Given this list of marker genes Trpc7, Vps53, Sncg, Pam, Mapk8ip1, Arfgef1, Atn1, Cdkn1a, Map6, Adgrv1, Nrbp1, Bag5, Plcg2, Pdcl3, Vcp, Slc39a9, Clint1, Vamp8, Ros1, Nanos2 (nanos C2HC-type zinc finger 2), Nme1, Bicd1, Ccnt2, Ankrd13c, Vps4a, Pdlim4 (PDZ and LIM domain 4), Selenom, Zftraf1, Fzd9, Epg5, Pum2, Bcl3, Rtraf, Pde9a, Traip, Synj2bp, Twf2, Exoc1, Atp2a1, Ccl2, Traf6, Cherp (NCBI Gene Id 70519), Maf1, Msn, Angel1, Nox4, Cask, Prkcg, Ankrd13a, Aldob, Erbb2, Dgki, Ctsb, Kif1a, Cdk2ap1, Tpd52l1, Nedd4, Mgat1, Trf, Cul7, Park7, Calcoco2, Galnt3, Sorl1, Hspa1b (NCBI Gene Id 15511), Vldlr, Capn6, Serhl, Slc2a4, Clic4, Map2k1, Myo5b, Rps6kb1 (ribosomal protein S6 kinase, polypeptide 1), Tnks2, Plscr2, Ccnf, Pstpip1, Nppb, Traf4, Tnfsf12, Gdpd5, Vamp3 (NCBI Gene Id 320838), Eif4a1, Tyr, Trim13, Myo9b, Cripto, Thbs3, Atp6v0a2, Hrnr, Ctif, Clic1, Sort1 (NCBI Gene Id 99747), Trim68, Usp20, Syt4, S100a13, Vps33b, Tg, Tesk1, Trim37, Galnt6 (polypeptide N-acetylgalactosaminyltransferase 6), Dnm3, Inpp5k, Oas2, Pde4a, Brsk2, Golga1 (NCBI Gene Id 99313), Adam10, Olfm4, Gsdma2, Ache, Ifitm3, Mob2, Plcz1, Mtmr2, Kalrn, Mcm3, Csnk1d, Bax, Cdh13, Calr, Cops8, Usp33, Ntm, Akip1, Osbpl7, Flrt1, Coro1b, Rab1b, Gak (cyclin G associated kinase), Flna, Traf7, Nfatc1, Cnp, Ccdc38, Magee1, Sirt2, Car4, Ncoa3, Acsl3, Ptprm, Capzb, Tmem100 (transmembrane protein 100), Aqp2, Btk, Alox5, Srfbp1, Nlrc3, Prkn, Klhl7, Npc1, Rnf207, Fasl, Snx5, Rbm4, Mapkap1, Hif1an, Atg7, Fmn2, Vti1a, Xkr8, Irag1, Itga2, Invs, Cdk19, Rps6, Aif1, Sipa1, Apc, Stmn3, Lamc2, Cyba, Cylc1, Cmya5, Map2k2, Stx16, Fam168b, Rab34, Mob4, Slc30a7, Slirp, Sh3gl2, Ppp1r16b, S100a6, Hyal2, Gc, Stx4a, Cdc5lrt1, Rab14, Cav2, Prkd1, Dnajb2, Rad51c (RAD51 paralog C), Ptges, Xrcc3, Ggps1, Rangrf, Jcad, Cyfip1, Cdc5lrt9, Mtpn, Vps52, Kcnd3, Snap47, Egfr, Chodl, Cideb, Ptk2, Cdc25c, Nppa, Aplp1, Stx6, Ldb3, Tmem184a, Kif5a, Flot2, Fzd5, Rab3ip, Cdkn3, Cdh1, Unc45b, Ckap4 (cytoskeleton-associated protein 4), Gad2, Itgb1bp1, S100a4, Cbl, Hip1r, Atp6v0a1, Tenm1, Ap1g1, Lrat, Cpd, Taf8, Epn3, Zdhhc19, Bri3, Ccar1, Osbpl1a, Tsc1, Usp2, Prkce, Csf1, Mrfap1 (Morf4 family associated protein 1), Nfkbie, Cep43, Cabp2 (calcium binding protein 2), Synj1, Bank1, Cops3, Cx3cr1, Ythdc2, Gtpbp4, Hmgcll1, Rep15, Prkcd, Rab3b, Trpc4ap, S100a16, Wwc1, Rasd1, Tsc2, Trappc2l, Atp7a (NCBI Gene Id 51824), Abl1, Crbn, Apex1, Aggf1, Lmtk2, Pde2a (phosphodiesterase 2A, cGMP-stimulated), Fyn, Insl3, Unc45a, Golga2, Pkhd1, Bdnf, Lmna, Syt5, Arfgef2, Atp2c2, Phex, Ddx6, Tmem192, Kcnh1, Mlc1, Gper1, Eif2ak2, Sorbs2, Dgat2, Gsdma3 (gasdermin A3), Cdc20, Myc, M6pr, Tollip, Lamb1, Mael, Tnfrsf1b, Aldh1a2 (NCBI Gene Id 19378), Nupr1, Septin12, Cln5, Anp32a, Sec16a, Pkp4, Plec, Mad2l1, Mobp, Bcl2, Rad50, Dab1, Sptbn2, Kcnb1, Cobl, Gsn, Itpr1, Ncs1, Osbp, Sprr3, Pdcd6, Nmral1, Hsp90b1, Adgrb1, Vps50, Hspa1a, Fxr1, Gbp2b, Stk33, Anp32-ps, Fbxw7, Ubqln1, Lpxn, Ica1, Mmd2, Akr1b1, S100a14, Kcns1, Ighmbp2, Nos2, Ggn, Myo16, S100b, Wdr44, Septin14, Rapgef2, Atp2a2, Fsd2, Uso1, Lrp1, Meis2, Dph3 (NCBI Gene Id 75408), Kif5b, Chga, Zdhhc8, Hcrt, Asic3, Scn5a, Trak1, Itgb1, Actl9, Slc2a12, Tamalin, Trarg1, Gnas, Gdpd1, Mx2 (MX dynamin-like GTPase 2), Bcl10, Pex5l, Rac3, Galnt4, Apba1, Igf2bp1, Kcns2, Daam1, Slc9a1, Ehd1, Fgfr1 (fibroblast growth factor receptor 1), Cerkl, Hmbs, Tspan1, Pld1, Syt6, Rapgef1, Gdpd3, Stk16, Map1s, Srd5a1, Cav1, Ece1, Endog, Aurka, Pacsin1, Kat5, Myo1b, Akap5, Dmtn, Th, Cdk5r1, Apc2, Pik3r1, Hap1, Shtn1, Pkp1, Cdc5lrt6, Tpd52, Eif4h, Pacs1, Ndor1, Pick1, Tppp, Psmc3, Rnf128 (NCBI Gene Id 66889), Dnaja1, Vapa (vesicle-associated membrane protein, associated protein A), Mt3, Trappc12, Wbp2nl (WBP2 N-terminal like), Optn, Inhbb, Sync, Vamp2, Tsnaxip1, Lce1d, Aftph, Ankrd13b, Ccdc42, Zpr1, Map1b, Cacna1g, Map3k4, Syt11, Emp2, Ppib, Prdx5, Rhbdd2, Dnm2, Mlf1, Ctnnb1, Dcun1d3, Mvp, Naa15, Ndfip2, Tpd52l2, Ryr1, Galnt2, Sec31a, Arf3, Rasef, Fat1, Scel, Rab8b, Rab40b, Tlr4, Nxt2, Tgfa, Pkn2, Ccng1, Abcc5, Neurl1a, Sele, Rasip1, Pde4b, Ankrd13d, Nat8f3, Dync1i1, Pla2g5, Lamp1, Dlg1, Atraid, Slc34a1, Tarbp2, Akap6, Grip1, Aatk, Map7, Gabarap, Hcn4, Spink5, Cx3cl1, Rad51, Kif20b, Osbpl3, Rd3, Fkbp4, Rab15, Magi2, Noct, Cts7, Camk2d, Trp53bp2, Taf10, Slc39a13, Mx1, Twf1, Tnik, Xiap, Bnip2, Ccr2, Faf1, Reg1, Igf2r, Arhgap1, Tgm2, Prdx6, Osbpl2, Laptm5, Hhatl, Azin2, Foxr1, Rara, Prkcz, Asgr2 (NCBI Gene Id 11890), Odc1, Hmgb2, Gad1, Htt, Lamp2, Serbp1, Itpr3, Slc8a3, Pink1, Ndrg1, Uaca, Galnt1, Bysl, Dab2, Rack1, Dctn3, Ccdc78, Anxa4, Stxbp1, Cdc5lrt10, Cyld, Vps35, Nanos3, Kcnma1, Ofcc1, Cert1, Mogat2, Amfr, Dpm2, Gbp3, Sec23b, Tra2b, Cabp1, Rangap1, Eif2ak3, Tnfsf13b, Pla2g4a, Hsp90aa1, Def6, Spmip6, Nherf1, Zdhhc20, Dicer1 (NCBI Gene Id 68462), Ggt1, Apln (apelin), Mtmr14, Tfrc, Nell1, Atxn2, Patj, Hdac1, Stom, Atp9a (ATPase, class II, type 9A), Add1, Mtmr9, Rab2a, Cst3, S100a7l2, Exoc8, Bag1, Nanos1, Cpeb4, Per2, Rab29, Inf2, Sec23a, Procr, Kcnd2, Lgmn, Ehd3, Lrpprc, Snx1, Snca, Stx7, Serpinf1, Klhl20, Sbf2, Fus, Ezr, Ryr3, Prex1, Dbi, Ndrg2, Cabp7 (calcium binding protein 7), Nos1, Eml1, Osbpl6, Hectd3, Upf1, Stbd1, Ranbp2, Aifm1, Ighm, Eif4e, Myo6, Actn4, St8sia2, Usp29, Arf5, Hmox1, Ywhab, Clu, Sgk1, Bud23, Stmn2, Vti1b, Atp9b, Ubqln4, Mospd1, Stc2, Abca1, Nhlrc1, Ctsj, Ehd2, Exoc3, Cldn19, Relt, Akap4, Hspa8 (heat shock protein 8), Capn2 (calpain 2), Lcp1, Akap13, Alox12b, Exoc6, Tnrc6a, Ptgds, Fbxl5, Agtr2, Sh3rf1, Ybx1, Dst, Osbp2, Slc2a10, Ndfip1, Apod, Trmt112, Myrip, Ptch1, Heph, Trappc2b, Cdk4, Hnrnpl, Itm2c, Nf2, Mapre3, Cybb, Slc11a2, Rab3a, Cib1, Cyb5r4, Prdx6b (peroxiredoxin 6B), Vamp5, Gsk3b, Enpp3, Cisd2, Slc17a3, Ptk2b, Pla2g2a, Prr7, Cdc5l, Epha5, Ywhaz, Rab5a, Ddx4, Adipoq, Cdc5lrt4, Cdk7, Caln1, Opn1sw (opsin 1 (cone pigments), short-wave-sensitive (color blindness, tritan)), Zfp105, Ppp1r13b, Set (NCBI Gene Id 80406), Gskip, App, Eif4a2, Picalm, Plvap, Manf, Rasgrp3, Sting1, Ptn, Prkar2a, Krt9, Pparg, Syp, Slc5a1, Ntrk2, Septin2, Bptf, Snap25, Ak1, Ptov1, Rab4b (RAB4B, member RAS oncogene family), Vps54, Grk3, Dmd, Zfyve1, Atxn10, Snf8, Dock6, Spire1, Sprr1b, Whrn, Gbp4, Bub1b, Bspry, Pclo, Nme2, Cypt1, Synrg, Syap1, Lyn, Tek, Pmp22, Cyfip2, Gjb2, Mapk8ip3, Ubr5, Hsf1, Pclaf, Sec23ip, Ttbk1, Prkra, Jag2, Prkca, Vdr, Slc39a12, Stat1 (signal transducer and activator of transcription 1), Tppp3, Cd34, Cdk5rap2, Psmf1 (proteasome (prosome, macropain) inhibitor subunit 1), Wrnip1, Arhgap10, Cpeb1, Rab4a (NCBI Gene Id 19341, RAB4A, member RAS oncogene family), Rnf41, Lnpep, Apbb1, Rab10, Heatr5b, Cdc5lrt8, Dbn1, Adcy10, Synj2, Cdkl5, Pcsk9, Ppm1f, Cntrl, Itga3 (NCBI Gene Id 16400), Bcap31, Malt1, Prkaca, Cep250, Esr1, Nicol1, Axin1, Eif3g (NCBI Gene Id 53356, eukaryotic translation initiation factor 3, subunit G), Hfe, Rhpn2, Ccin, Ank2, Septin9, Stk26, Obsl1, Atp7b, Pkn3, Mre11a, Lims1, Sez6, Ptges3, Kirrel1, Disc1, Abcd1, Upf2, Srcap (NCBI Gene Id 69360), Aspscr1, Esr2, Tmem134 (transmembrane protein 134), Rapgef3, Vps33a, Vim, Dnajb6, Rap1a, Fbxw8, Ctla4, Src, Asl, Apba3, Aanat, Mtdh, Prkar2b, Gbp5, Cdk2ap1rt, Kcna5, Pikfyve (NCBI Gene Id 71407), Slk, Tlk2, Spp1, Mlph, Creb3l2, Plaat3, Rab40c, Slc5a3, Rab3c, Krt18, Hdac6, Gbp2, Spag9, Ptpn22, Ncor1, Anxa6 (annexin A6), Cdc5lrt7, Lamp3, Pcsk1, Taok1, Depdc5, Kcnh2, Fas, Limk1, Casc3, Trappc2, Avpr2, Spata32, Mex3d, Spast, P2rx4, Sbf1, Stx8, Fgfr3, Cdc5lrt5, Plekhf1, Dnm1l, Gnb2, Fignl1, Inhba, Npy, Limk2, Plekhg5, Atcay, Actr3, Pak2, Plscr1, Ltbp1, Anxa2, Gsdma, Ehd4, Tsnax, Rab38, Cd2ap, Snapin, Ccn2, Prkacb, Pafah1b1, Cops5, Fmr1, Hsp90ab1, here is a description of the gene set: Cytoplasm situated near, or occurring around, the nucleus. Mouse Gene Set: GOCC_PERINUCLEAR_REGION_OF_CYTOPLASM species: Mus musculus